Given this list of marker genes Bcl2, Sh2d1a, Dtx1, Apobec3, Ccnd3, Pik3ip1, here is a description of the gene set: Mouse Gene Set: CUI_T_CELL_GD_LIF_RESPONSE_UP from publication Cui A, Huang T, Li S, Ma A, Pérez JL, Sander C, Keskin DB, Wu CJ, Fraenkel E, Hacohen N (PMID 38057668) Genes positively differentially expressed in cell type: γδ T cell upon treatment with cytokine: LIF in mouse lymph nodes in vivo. Cytokines mediate cell-cell communication in the immune system and represent important therapeutic targets. A myriad of studies have highlighted their central role in immune function, yet we lack a global view of the cellular responses of each immune cell type to each cytokine. To address this gap, the authors created the Immune Dictionary, a compendium of single-cell transcriptomic profiles of more than 17 immune cell types in response to each of 86 cytokines (>1,400 cytokine-cell type combinations) in mouse lymph nodes in vivo. A cytokine-centric view of the dictionary revealed that most cytokines induce highly cell-type-specific responses. For example, the inflammatory cytokine interleukin-1β induces distinct gene programmes in almost every cell type. A cell-type-centric view of the dictionary identified more than 66 cytokine-driven cellular polarization states across immune cell types, including previously uncharacterized states such as an interleukin-18-induced polyfunctional natural killer cell state. studied in species Mus musculus